The following is a description of a gene set: studied in species Homo sapiens Genes down-regulated in comparison of dendritic cells (DC) exposed to 50 worm/well B. malayi versus macrophages exposed to 50 worms/well B. malayi. Monocyte-derived dendritic cells (DC) and macrophages (MΦ) generated in vitro from the same individual blood donors were exposed to five different pathogens, and gene expression profiles were assessed by microarray analysis. Responses to Mycobacterium tuberculosis and to phylogenetically distinct protozoan (Leishmania major, L. donovani, Toxoplasma gondii) and helminth (Brugia malayi) parasites were examined, each of which produces chronic infections in humans yet vary considerably in the nature of the immune responses they trigger. Human Gene Set: GSE360_DC_VS_MAC_B_MALAYI_HIGH_DOSE_DN from publication Chaussabel D, Semnani RT, McDowell MA, Sacks D, Sher A, Nutman TB (PMID 12663451), and this is the list of marker genes: BAG6, CCL5, EXOC6B, UCHL3, HOMER3, ABCC6, LSS, PPP1R15A, RLBP1, DHCR7, ITSN1, COL6A2, MAP2K3, ALDOC, DHRS3, FKBP2, GPC4, IFI16, BST2, FDPS, CD300A, TRIM21, VAMP2, CTSK, FAH, PTGER2, CD14, NDUFS3, CA4, STX7, MYDGF, HSD11B2, MX1, PDXDC1, CASC3, IGF1 (NCBI Gene Id 3479), TUBB2A, P2RX4, CLN3, LMF2, SLC39A8, HPCAL1, IFNG (interferon gamma), EMILIN1, APLP1, LPAR2, HIVEP2, RAB27A, MT2A, MAFF, RAB11FIP5, SELENOP, TSC22D3, SAT1, SELL (selectin L), GPR3, CHD3, MT1B, RGS16, SCN9A, MYO1F, CBARP, IFI6, RTN1, ISG15, STK10, F3, TNFAIP2, LDLR, PTK2B, SPARC, NEU1, LSAMP, VCAN, ACVRL1, ATP2A2, TPI1 (triosephosphate isomerase 1), RPL3, PLK2, EEIG1, VGLL4, FCGBP, LILRA2, TLR1, CHMP2A, CTTN (NCBI Gene Id 2017), KRIT1, FADS1, DNAJC8, AMHR2, SNX15, GDF11, MT1F, CDK9, SNUPN, NUP188, MIF, FOXO3, MUSK, TNFRSF1B, GMPR, AMPD3, SERPINA1, EPHB2, KCNAB2, NUPR1, ENO2, FCAR, MMP9, S100A8, BPI, LAGE3, ADA, CDKN2A, TRIM22, ARAP1, BTN3A3 (NCBI Gene Id 135583), SMARCD3, KDSR (NCBI Gene Id 2531), COL2A1, SLC9A1, IDO1, DLEC1, NEDD4L, THOP1, CD247, CHMP7, LTA4H, S100A2, MSMO1, AMOTL2, ITGA3, WT1-AS, OAS2, CXCR2, TGFB1, GCDH, S100A13, KANK1, MYD88, IQSEC2, PPP3R1, EMP3, CALCOCO2, SLC11A1, PSME2, TALDO1, SMPD1, PLAUR, MT1H, TADA3, DNASE2, RNF103, MUC6, RRAS, ADCY3, DDIT4, FCMR, TMEM131L, RHOC, TBXA2R (thromboxane A2 receptor), CD48, MPZL1, MSH4, TRIM27, CEBPD, DYNLT1, CADM1, RGS1, RTCB, GPC3, OPTN, FSCN1, SSNA1, GLRX, TP53I11, CALM3, FXR2, RRBP1, SREBF2, DENND3, PDIA4, HDAC5, TYMP, PARK7, GNB3, NSDHL, HRAS, H2BC21, CD163, OMG, AASS, KCNB2, MGLL, LILRB5, PTGIR, IFI44, CD300C, CIR1, H1-0